Given this list of marker genes ANXA2, F12, CLEC3B, ENO1, MELTF, S100A10, HPN, PLGRKT, here is a description of the gene set: studied in species Homo sapiens Human Gene Set: GOBP_POSITIVE_REGULATION_OF_PLASMINOGEN_ACTIVATION Any process that increases the rate, frequency or extent of plasminogen activation. Plasminogen activation is the process in which plasminogen is processed to plasmin.